Given this list of marker genes FGG, VWA5A, FCGBP, CXADR, TRAPPC3, ZNF318, AGPAT1, MED22, TMOD1, PIGL, CENPS, SYT11, PART1, APOBEC3B, CD27, COX7A1, BCL7A, PDZRN3, ENDOU, SPECC1L, EPRS1, LAPTM5, CD6, NPPB, SNHG3, VOPP1, PDE3B, IVL, TGFB1, ING1, NDST1, POMC, PLS3, DCBLD2, PTK2B, TLE4, PTPN14, RDH11, VCAN, CTRL, LY9, RLN2, MSC, POU2AF1, PAFAH1B1, GLS, RFX5, MYOD1, FAM3C, PIR, PDE8A (NCBI Gene Id 5151), BST2, PICK1, ID3, UGP2, FAM76A, CSN2 (NCBI Gene Id 1447), MDFIC, CYP27A1, SNAP25, LCN1, JAK2, TNK2, EDNRB, MAN2B2, AHDC1, ZCCHC24, LPAR4, TBXA2R, P2RX7, IL16, SH3GLB1, TPBG, IL11, SPOCK2, MINPP1, CACNG1, STK25, IGF1, GATA6, CD84, PRPH, HOXA1, FETUB, GNMT, CTDSPL, RPL39, ACTG1, POU2F2 (POU class 2 homeobox 2), HLA-DRB6, HCAR3, NR4A2, SAMHD1, WBP1L, PGAP1, CKMT2, TNFRSF10C (TNF receptor superfamily member 10c), BST1, NOS1, TP53I11, CD9, EGF, KDM7A, PTCRA, WWC1, CREBZF, PCSK1, PPFIA4, HMHB1, SLC22A5, THSD7A, PSMB8 (proteasome 20S subunit beta 8), IGFBP4, ITGA9, EPHB6, ISG20, DHRS3, FDX1, SLC10A3, RBM5, MARCHF2, LAPTM4B, LAMA5, RALGAPB, SLC11A1, ADGRE5, GPR182, PCYT1B, GRK3, GMPR, POLD3, PTTG1, RORB, OVOL3, KIF1A, IRF1, SLC9A1, BTBD8, PCDH7, ARHGAP19, PFKM, THBS2, PLEK, COL6A3, TACSTD2, ECM1, GRIK2 (NCBI Gene Id 2898), COL6A1 (NCBI Gene Id 1291), HLTF, LTBP4, SPART, FLNB, PRKAB1, FN1, LIPT1, LYPD3, SERPINB8, PLP2, ESYT1, ITGA1, STK38L, RGS16, PRKD2, PLD3, CCDC28A, TRIP6, GNG7, ERN1, GJC1, INSL4, CNTN1, CXCL2, IDS, REEP2, ZW10, CCL20, GBP2, EPHA4, RDH5, ZP2, MYO10, XRCC2 (X-ray repair cross complementing 2), CEL, CYRIA, OLIG2, IPCEF1, RAB29, SGSM3, PUM2, PRM1, BMP2K, PASK, AP1S1, DLEU2, ARB2A (ARB2 cotranscriptional regulator A), ZNF529, HBP1, ABO, ITGA5, here is a description of the gene set: from publication Lee JH, Ulrich B, Cho J, Park J, Kim CH (PMID 21768398) Genes up-regulated in CD4 T cells: TGFB1 versus TGFB1 and progesterone. We examined the global gene expression pattern of T cells regulated by progesterone to gain further insights into the regulatory mechanisms of progesterone. We found 325-347 cord blood T cell genes up or down-regulated by P4 in the presence or absence of exogenous TGFb1. Peripheral blood T cells were relatively unresponsive with only 30-genes regulated by P4. IL-6 receptor (IL-6R) expression was greatly down-regulated by progesterone in cord blood, but not PB, T cells. Overall, these differences in gene expression are consistent with the differential responses of cord blood and peripheral blood T cells to progesterone. To gain insights into the differences of progesterone and control dendritic cells, we performed a microarray study and found ~genes regulated by progesterone in dendritic cells. The gene expression information suggests that progesterone has the potential to alter dendritic cell responses to cytokines, chemokine production, and migration which in combination would control T cell differentiation. Human Gene Set: GSE22025_TGFB1_VS_TGFB1_AND_PROGESTERONE_TREATED_CD4_TCELL_UP species: Homo sapiens